The following is a description of a gene set: The chemical reactions and pathways involving dicarboxylic acids, any organic acid containing two carboxyl (COOH) groups or anions (COO-). species: Homo sapiens Human Gene Set: GOBP_DICARBOXYLIC_ACID_METABOLIC_PROCESS, and this is the list of marker genes: SLC46A1, SUCLG2, NR1H4, SLC38A8, FAHD2A, NAGS, COL6A1, HOGA1, ALDH18A1, DGLUCY, ACSF3, SDHAF3, SDHA, MTRR, NIT2, MTHFS, PRODH2, IDH1, GAD2, GPT2, GLS, UROC1, SLC25A32, ASPA, PCK2, GAD1, HAL, ME1, ATCAY, GGT1, SUCLA2, ALDH5A1, IDO1, FH, KGD4, DLD, ALDH4A1, GOT1, HAAO, ASS1, GLS2, MTHFD1L, GLUD1, ADSS1, FAHD1, OAT, TAT, PRODH, OGDH (oxoglutarate dehydrogenase), MTHFD1, MDH2, MDH1B, SHMT1, GCLM, DLST, DHFR2, QPRT, MTHFD2L, L2HGDH, SLC7A11, ACLY, ACOT8, DDO, LIPF, ME2, AMDHD1, ACMSD, FPGS, D2HGDH, BLOC1S6, FTCD, DHFRP1, MDH1, SDHB, IDH2, ATIC, DHFR, ALDH1L2, MTHFD2, ME3, ASL, ADSS2, GRHPR, KYNU, PCK1, FAHD2B, GLUL, GCLC, OGDHL, GOT2, SLC19A1, FOLR1, ALDH1L1, AADAT, ADHFE1, KMO, KYAT3, AASDHPPT, ACOT4, GLUD2, PHYH, GOT1L1, PM20D2